Given this list of marker genes Dnajb1, Nfkbia, Pkd2, Daxx, Pkd1, Ddit3, Sri, Id3, Tcf23, Taf1, Sin3a, Id4, Tfdp1, Per2, Smad7, Nkx3-1, Uaca, Lef1, Elk1, Id1, Zfp451, Hexim1, Trappc2b, Smad6, Taf3, Keap1, Nfkbil1, Pura, Nr0b2, Snip1, Lyar (NCBI Gene Id 17089), Id2, Hes6, here is a description of the gene set: Mouse Gene Set: GOMF_TRANSCRIPTION_REGULATOR_INHIBITOR_ACTIVITY species: Mus musculus A molecular function regulator that inhibits the activity of a transcription regulator via direct binding and/or post-translational modification.